The following is a description of a gene set: Gap-filling DNA repair synthesis and ligation in GG-NER Mouse Gene Set: REACTOME_GAP_FILLING_DNA_REPAIR_SYNTHESIS_AND_LIGATION_IN_GG_NER species: Mus musculus, and this is the list of marker genes: Rps27a, Rfc5, Rpa2, Ubb, Rfc3, Pole, Ubc, Pole4, Uba52, Rpa3, Uba52rt, Pold4, Rfc1, Polk, Pold1, Rpa1, Pole3, Rfc4, Pcna, Pold3, Pold2, Rfc2, Pole2